Given this list of marker genes EFNB1, HNRNPK, CENPJ, H4C3 (NCBI Gene Id 8364), BCOR, SCNM1, HSPA9, RNU4-2, ALX4, NAA10, FREM1, KAT6A (lysine acetyltransferase 6A), ZSWIM6, FRMPD4, CDH11, ATP6V1B2, ALX3, FZD2, NEK1 (NIMA related kinase 1), here is a description of the gene set: studied in species Homo sapiens A splitting of the nasal tip. Visually assessable vertical indentation, cleft, or depression of the nasal tip. Human Gene Set: HP_BIFID_NASAL_TIP Bifid nasal tip